The following is a description of a gene set: Accumulation of granular osmiophilic material in blood vessel walls. Osmiophilic material becomes black upon staining with osmium tetroxide. Deposition of granular osmiophilic material (GOM) is the vascular pathological hallmark of CADASIL, which is the most prevalent hereditary small vessel disease and is caused by missense mutations in the NOTCH3 gene. GOM have been shown to contain NOTCH3 ectodomain (NOTCH3ECD) and extracellular matrix proteins, and can be visualized ultrastructurally in the tunica media of small arteries and capillaries. These electron dense GOM deposits are located in the basement membrane of mural cells, i.e. vascular smooth muscle cells and pericytes. In both manifest and pre-manifest CADASIL patients, GOM deposits are present not only in brain vessels, but also in vessels of other organs, such as the skin. Human Gene Set: HP_VASCULAR_GRANULAR_OSMIOPHILIC_MATERIAL_DEPOSITION Vascular granular osmiophilic material deposition species: Homo sapiens, and this is the list of marker genes: CLN6, CTSD, NOTCH3, PPT1, CLN8, DNAJC5, HTRA1